The following is a description of a gene set: Human Gene Set: YYCATTCAWW_UNKNOWN studied in species Homo sapiens Genes having at least one occurrence of the highly conserved motif M52 YYCATTCAWW in the regions spanning 4 kb centered on their transcription starting sites. The motif does not match any known transcription factor binding site. from publication Xie X, Lu J, Kulbokas EJ, Golub TR, Mootha V, Lindblad-Toh K, Lander ES, Kellis M (PMID 15735639) Comprehensive identification of all functional elements encoded in the human genome is a fundamental need in biomedical research. Here, we present a comparative analysis of the human, mouse, rat and dog genomes to create a systematic catalogue of common regulatory motifs in promoters and 3' untranslated regions (3' UTRs). The promoter analysis yields 174 candidate motifs, including most previously known transcription-factor binding sites and 105 new motifs. The 3'-UTR analysis yields 106 motifs likely to be involved in post-transcriptional regulation. Nearly one-half are associated with microRNAs (miRNAs), leading to the discovery of many new miRNA genes and their likely target genes. Our results suggest that previous estimates of the number of human miRNA genes were low, and that miRNAs regulate at least 20% of human genes. The overall results provide a systematic view of gene regulation in the human, which will be refined as additional mammalian genomes become available., and this is the list of marker genes: ATP5MC1, PRKAR2B, TOMM40, GOLT1B, XPO1, AGTR2, IGF2BP3, RAPH1, INHBA, TP63, CDC40, TNFSF11, FILIP1, PPM1A, RAB30, NRK, KRTAP13-2, PAPPA, MYO1C, VAX1, RHEBL1, BMP7, PLCB2, HOXB7, UBE2E1, TCF15, TIAL1, DPF1, RWDD2A, ADNP, FYN, TRIB2, FOXG1, CCN1, CDC14A, LIF, DNM1L, SMARCA4, EMID1, CLTC, TOB1, NEDD4, FGFR3, DDA1, ATF7IP, SPRYD3, BRMS1, KLF12, DCLK1, RFX4, DIO2, MYO9A, USP7, ANGPT2, AAK1, NFIA, RAB35, COX8A (NCBI Gene Id 1351), SP4, AZIN1, NEUROD6 (NCBI Gene Id 63974), GALE, DUSP4, ASIC2, GDPD5, BASP1, ETS2, PLA2G3, ERBB4, TSPAN13, PTPN11, DAAM1, GPR3, GCLC, B3GNT6, ZNF668, ATF3, IGF1R, SMAP2, EPO, DLX1, TRMT2A, SALL3, DLEU1, FOXD3 (NCBI Gene Id 373071), NF2, HCRTR1 (hypocretin receptor 1), MAFF, VDAC2, CRYBG2, GRHL3, SCG2 (NCBI Gene Id 7857), GPM6A, CHD6, KCNB2, RGS3, SCN3A, E2F3, DNAJC22, CALM1, RAB5C, GABRA1, KATNB1, PLPP3, USP14, PPA1, RUNX1, EIF4E, MYH2, SHISA6, RECQL, DLEU2, SCG3, ZCCHC17, CKB, EPHB2, SENP8, MCC, RANBP1, NCS1, P4HA1, GGN, SNRNP40, EVI5L, EP300, ETV4, ELOVL6, LGALS3, UBALD2, CASK, TSC1, LMNB1, WASF1, HTT, PRSS27, CCND1 (cyclin D1), FOSL1, EBAG9, CHD2, GAP43, CORO1A, SLC26A7, CEP95, NR4A3, TPM3, MFSD2A, NUP98, LAMA1, KCNQ5, UBE2S, DPY19L3, SAPCD2, FLI1, USP10, BRINP3, ZBTB17, UBE2N, CCSER2, TUBA1A, VCAN, ANK3, EEF1G, LRP8, RBPJ, PGM3, PDE4B, CDC7, LOXL4 (NCBI Gene Id 84171), EFEMP2, TMEM59L, DMD, ZNF646, ETV5, DDR2, ACVR2A, ARB2A, MED12L, NAA15, DNAJB5, DDX5, ZDHHC21, TMEM256, SKAP1, CPS1, SPRY4, CBARP, MXI1, LANCL3, FOSB, PIP4K2B, ID1, AP1B1 (NCBI Gene Id 162)